The following is a description of a gene set: Human Gene Set: GOMF_SINGLE_STRANDED_DNA_EXODEOXYRIBONUCLEASE_ACTIVITY species: Homo sapiens Catalysis of the sequential cleavage of mononucleotides from a free 5' or 3' terminus of a single-stranded DNA molecule., and this is the list of marker genes: MGME1, ISG20, EXO5, POLE, EXD2, EXO1, POLG, PLD3, MEIOB, PLD4